Given this list of marker genes Sirt7, Bud23, Heatr1, Riok2, Riok1, Utp15 (NCBI Gene Id 218488), Wdr43, Trmt112, Wdr75, Dimt1 (DIM1 rRNA methyltransferase and ribosome maturation factor), here is a description of the gene set: Mouse Gene Set: GOBP_POSITIVE_REGULATION_OF_RRNA_PROCESSING species: Mus musculus Any process that activates or increases the frequency, rate or extent of rRNA processing.